The following is a description of a gene set: species: Mus musculus Mouse Gene Set: GOMF_ALPHA_ACTININ_BINDING Binding to alpha-actinin, one of a family of proteins that cross-link F-actin as antiparallel homodimers. Alpha-actinin has a molecular mass of 93-103 KDa; at the N-terminus there are two calponin homology domains, at the C-terminus there are two EF-hands. These two domains are connected by the rod domain. This domain is formed by triple-helical spectrin repeats., and this is the list of marker genes: Cacna1d, Alms1, Dag1, Synpo2, Lrrc10, Pdlim5, Magi1, Nphs1, Itgb1, Adora2a, Nrap, Pdlim1, Pdlim3, Pkd2l1, Xirp2, Prickle4, Cacna1c, Pdlim4, Ldb3, Kcnn2, Pkd2, Kcna5, Pparg, Pdlim2, Mypn, Ttn, Ptprt, Rara, Pdlim7, Myot